Given this list of marker genes ANP32A, TSHZ1, LIX1L, ZNF362, SEL1L3, TTC13, USP49, ARL6IP6, SLC6A15, SREK1IP1, SIKE1, JADE1, MFSD14A, CAVIN1, GTF2H3, ZNF454 (NCBI Gene Id 285676), RNF214, NOTCH1, SLC35A3, MFSD4A, MAP2K6, DPY19L4, OPA3, ZNF800, RING1, TRAK2, DLG2, SPAST, CLEC2D, ZIC5, CLEC4D, XKR3, MTREX, MBTD1, LRP11, AMMECR1, C1orf21, STXBP5, ACOX1, MAP3K7CL, DOCK2, RBIS (NCBI Gene Id 401466), CPPED1, PYGO1, RAC3, LMO2, ALCAM, REV3L, GCLC, SYNE3, APLN, BTBD1, CSMD2, NUP188, CLDND1, RAP1A, JAK2, SUMO4, NOTCH2NLA, APOOL, RGS5, ADAMTS1, VIRMA, PPP1CC, PDE3A, SS18L1, NUFIP2, C10orf88, CFAP69, BLZF1 (basic leucine zipper nuclear factor 1), CCNL1, EREG, NBEA, STIP1, SOX1, YY1 (YY1 transcription factor), HGF, KLF8, ERAP1, FZD6, YIPF4, ZNF684, TMPRSS11E, PLEKHA3, PCBD2, BACE1, WRAP73, TMEM132B, TRIP10, ZNF621, GAB1, DPH5, ADK, CCL1, NHS, KIF20B, SLC7A11, CYP26B1, FAM91A1, GPATCH2L, PLCL2, INSC, RIMOC1, KMT2E, CHST9 (NCBI Gene Id 83539), PPIL2, INTS6L, SPPL3, AKIRIN1, PALB2, MSL2, GPR6, RAP2A, CHP2, FBXO8, MAML2, HEXA, TBR1, FRMD6, PRDM1, TJP1, ZNF268, ABHD13, CFAP91, TSHZ3, ARFGEF3, CCER1, FBXO38, FHOD3, RGS21, MFAP2, EFNA1, MEOX2, POSTN, VCPKMT, PIEZO1, ZC3H18, REST, PGM3, PTPN4, PTPRG, NFAT5, MATN2, MIER3, LRRC7, LYPD6B, CCDC144A, ARMCX4, USP44, MCC, FST, SMTNL2, MYCBP2, CDK4, DGKH, SNX2, FRMD4B, GRM8, PTRH1, HOXD13, RHOBTB1, SLC17A2, POLR1F, HTR1F, SZRD1, BVES, PLD5, AGFG1, MCTP1, NEUROD1, IRX2, ZMYND11, C2, RBM11, CACNA2D1, NGF, AP3M2, MFSD14B, TET2, DKK2, ZFX, LRP1B, CADM2, USP45, ELAVL2, PURA, ESCO2, PGAP1, COL6A3, PROSER2, NIPBL, WNT3, ZC3H12B, MED14, JRKL, FUT9, PHC3, CTNNA3, SEPTIN10, RBM20, CLK2, PHIP, PWP1, CNTN5, TAF1L, NR2C2, FCF1, CCDC141, RNF217, ARL4C, ACKR4, DUSP1, RIC3, SH3BP5, NOC3L, PRXL2C, LIMCH1, SLC16A10, GLCE, NETO1, CMTM6, NR4A3, JAK1, RAB20, STOX1, TXNDC9, ZKSCAN7, STAMBPL1, SHE, RHOT1, ANGPT2, FOSL1 (FOS like 1, AP-1 transcription factor subunit), SGCZ, COL13A1, ZSWIM6, NRG1, RORB, ELAPOR1, ZDHHC3, CAMK4, ZNF736, SIX4, ENPEP, ACVR1C, RAMAC, SERTAD2, CD40, LCORL, UNC80, ACTR6, ID2, RNF145, KLF12, IFNL1, FAM13C, SPOPL, GATA6, BEND3, SOCS4, PAX3, FGL2, FKBP14, ZBTB41, SLC1A3, KCNMB2, SMURF2, CDCA7, here is a description of the gene set: from publication Chen Y, Wang X (PMID 31504780) studied in species Homo sapiens Genes predicted to be targets of miRBase v22 microRNA hsa-miR-568 in miRDB v6.0 with MirTarget v4 prediction scores > 80 (high confidence targets). Human Gene Set: MIR568